The following is a description of a gene set: Any process that stops, prevents, or reduces the frequency, rate, or extent of interleukin-10 production. Mouse Gene Set: GOBP_NEGATIVE_REGULATION_OF_INTERLEUKIN_10_PRODUCTION studied in species Mus musculus, and this is the list of marker genes: Ager, Lilrb4b, Prg2, Vsir, Ido1, Trib2, Foxp3, Pdcd1lg2, Il23r, Cd274, Btk, Mir98, Fcgr2b, Tyrobp, Il23a, Tnfrsf21, Lilrb4a, Jak3, Cd84, Dll1, Epx, Il12b